Given this list of marker genes Dbt, Ivd, Bcat2, Mccc2, Auh, Mcrip2, Acad8 (NCBI Gene Id 66948), Hmgcll1, Acat1, Slc25a44, Ppm1k, Aldh6a1, Bckdha, Hmgcl (NCBI Gene Id 230831, 3-hydroxy-3-methylglutaryl-Coenzyme A lyase), Hsd17b10, Ilvbl, Bckdk, Acadsb, Hibadh, Hibch, Dld, Dao, Bckdhb (branched chain ketoacid dehydrogenase E1, beta polypeptide), Bcat1, Mccc1, here is a description of the gene set: studied in species Mus musculus Mouse Gene Set: GOBP_BRANCHED_CHAIN_AMINO_ACID_METABOLIC_PROCESS The chemical reactions and pathways involving amino acids containing a branched carbon skeleton, comprising isoleucine, leucine and valine.